Given this list of marker genes KLHL7 (kelch like family member 7), SCN2A, SAMHD1, SYT2, PUS3, GABRA1, AGRN, SFTPA1, NKX2-6, CAPNS1, LSM11, TERC, PCK1, ABCA3, MT-CYB, VAMP1, SCN1A, LMNA, SCN9A, TBX1, ADAMTS19, NKX2-5, SFTPB, ADAR, SFTPA2, MYH6, ENPP1 (NCBI Gene Id 5167), ACTC1, SNAP25, SLC25A1, AK9, MMP21, NUP214, EIF2AK4, ENG, SCN1B, PLD1, IFIH1, PRKAG2, ZMPSTE24, GCSH, RAPSN, SLC2A1, RNASEH2A, GATA4, KCNQ2, MYO9A, RNASEH2B, HBG2, PLXND1, RBM10, ZIC3, CITED2, TMEM260, SLC25A20, PRRT2, ETHE1, FXN, GTPBP3, LRP4, CHRNB1, COQ4, KCNQ3 (potassium voltage-gated channel subfamily Q member 3), SLC34A2, RPS6KA3, MUSK, HBB, TREX1, COL1A1, HLA-DRB1, HSD17B10, SCN4A, TCF4, DOK7, ABCC6, COL5A1, HBA1, SEPTIN9, DSP (desmoplakin), CHRND, PSAT1, DPP9, COL5A2, AGXT, SLC25A3, CHRNA1, MVK (NCBI Gene Id 4598), GABRG2, NDUFS4, COL13A1, MYH7, PCDH19, ELP1, TLL1, PAX3, SLC5A7, CYB5R3, CHRNE, TXNDC15, RNU7-1, ACVRL1, GATA6, ATP11A, TERT, FUCA1, SFTPC, SCN8A, PARN, CYB5A (NCBI Gene Id 1528), SOX9, TBX20, GRIK2, SLC18A3, STN1, RTEL1, FAM13A, RNASEH2C, CHAT, MUC5B, here is a description of the gene set: Human Gene Set: HP_CYANOSIS studied in species Homo sapiens Bluish discoloration of the skin and mucosa due to poor circulation or inadequate oxygenation of arterial or capillary blood. Cyanosis